The following is a description of a gene set: species: Homo sapiens Genes predicted to be targets of miRBase v22 microRNA hsa-miR-7-2-3p in miRDB v6.0 with MirTarget v4 prediction scores > 80 (high confidence targets). Human Gene Set: MIR7_2_3P from publication Chen Y, Wang X (PMID 31504780), and this is the list of marker genes: FRMD4B, GDF6, FSTL1, ZNF823, PCDH18, ACTR10, ACYP2, EXOC6, ZFYVE16, VGLL4, SGCE, BTN3A1, BCAP29, PIK3CB (phosphatidylinositol-4,5-bisphosphate 3-kinase catalytic subunit beta), CLCA4, NOD1, PPFIA2 (PTPRF interacting protein alpha 2), SENP7, ITGA4, HSP90AA1, TMEM245, DCAF13, EXOC5, HMGCLL1, ESM1, TXLNB, WFS1, FPR3, CADM2, ADNP2, IDH1, RBM12, TAFA2, PPARGC1A, SNTG1, PDE3B, FGF7, IFT57, CCNG2, ITIH6, HDAC2, SLC7A7, AHR, MEF2D, THEMIS, N4BP2L1, SH3BGRL2 (NCBI Gene Id 83699), TRPV3, EPS15, SLC13A1, ASB5, PRELID3B, MLF1, TENT5A, RBM7, STXBP5, MECOM, KLHL24, ZBTB10, TOR1AIP2, SPP1, STAM2, NKAIN2, ZMYND11, NUFIP2, LRRC58, ZNF626, CXADR, SKAP2, DPYSL2, TPD52L1, FZD8, EEF1E1, CHN2, TMEFF2, CEP170, DCAF7, POU3F1, PNRC1, CDH19, CHRNA6, SLC5A7, REEP3, NAP1L1, FGFR1OP2 (FGFR1 oncogene partner 2), MACROD2, SLC19A2, PELI1, GABRA4, CTNND2, RFX7, BNIP2, CPEB2, PTGFRN, PDLIM5, INO80D, FBXL3 (F-box and leucine rich repeat protein 3), SMARCA2, MUC13, GPM6A, GULP1, MPHOSPH9, CNOT6, TTYH3, DMRT1, PSMA5, RNF111, OTUD6B, FGF2, BTF3L4, TP53INP1, TRPC1, ARHGEF7, FMN1, ARHGAP5, PDS5B, LRBA, ATP1A2, CDK1, SLC35A3, CRABP2, ATL2, TXNRD1, CDC73, ATP8A1, TMEM41B, RPE, ANKRD46, PNLIPRP3, FN1, C12orf56 (chromosome 12 open reading frame 56), UPRT, POLR3A, CTDSPL2, GPR158, PER3, ZMYM2 (NCBI Gene Id 7750), PRR23B, YOD1, TAL1, FNIP1, GTF2A1, OXNAD1, NEUROD6, MINDY2, CCDC126 (NCBI Gene Id 90693), PLPPR4, MAPK9, MTDH, MYNN, FGL2, PPHLN1, NETO2, DDX6, ROBO2, SCG2, SLC39A8, RIMBP2, AGMO, TIMM21, NELL2, TMEM132C, CAB39 (NCBI Gene Id 51719), TMED2, PFDN4, MPC1, BCL11A, SLC6A2 (NCBI Gene Id 6530), ZFHX4, BTBD10, ELL2, FBXL17, FSD1L, TMX3, KDM4A, RMI1, RSPO3, ANGPTL3, USP37, SETD2, ART3, NCAPG2, SYT14, MYCN, CBLN4, GPR22, CFAP206, KCTD9, ANKRD13C, AEBP2 (AE binding protein 2, NCBI Gene Id 121536), FYB1, EBF2, VGLL3, YTHDF3, RNF139, RAB3C, ELF1, HTR2C, TMEM65, SRSF11, TOR1AIP1, DIP2C, PHF20L1, HAPLN1, SLC25A16, FRMD3, CASP8AP2, HYCC1, ENO2, GTF2H3, SESN3, CDC23, MGAT4A (alpha-1,3-mannosyl-glycoprotein 4-beta-N-acetylglucosaminyltransferase A), GRK2, SCYL3, ZCRB1, TASP1, MSX1, OLA1, RORB, ZNF519, POLR3G, NFE2L2, SEC23IP, RIF1, FAM169A, SLC17A6, ASF1A, PCDH11X, KALRN, MVB12B, MSL3, PIWIL1, NUDT5, CDK14, GPC4, MAP3K2, ZBTB20, FAN1, KLF3, NHSL1, DMXL2, CC2D2B, SPTSSA, NTN4, PTGS2, SEC14L1, MYEF2, ABHD13, CAMSAP2, AQR, CFAP65 (cilia and flagella associated protein 65), PPP3CA, THBS2, SLAIN1, SCAF8, MBNL2, CCNT2, HTATSF1, CREBBP (NCBI Gene Id 1387), ANTXR2, FXR1, PSD3, SLC12A2, HCFC2, ONECUT2, LRRFIP1, HINT3, CFHR2, RIMKLB, RBM46, RBMS3, C5orf24, TENT4B, ZC3HAV1L, ASTN1, CALCR, KIF13A, DCUN1D5, FBXO28, RAB3IP, ITGB6, NUCKS1, GPR137B, ZFR, PAX3, DCAF12L1, VEGFA, MYSM1, NUP58, LCLAT1, CNR1, CDH8, PJA2, VPS26A, GOLGA6L9, KLF12, SMIM14, SNCA, PICALM, ARMCX1, FBXO9, USF3, CBLL1, BEND4, PIGM, GMEB1, SPCS2, KSR2, THAP2, ATAD1, ZNHIT6, TNPO1, NAP1L2, NMT2, RPS6KA3, MAST4, DNAH14, C10orf88, TRIM2, NRXN1 (NCBI Gene Id 9378), RAB2A, C5orf47, TGFBR3, PDGFA, COPB1, SF3B1, KHDRBS2 (NCBI Gene Id 202559), TOR1A, THRAP3, CHM, ATRX, NEK7, MAP7, CCSER2, BRWD3, DLX2, ENDOV, KLHL15, EPB41L3, PLEKHG4, PPP2R5E, PLD5, TMEM47, KCNC2, ARHGAP12, JADE1, FBXO45, KCNK2, PTPRF, BDNF, FOXN2, GPR17, CLDN11, FAM184A, FBXO30, MB21D2, PTAR1, HDAC9, WIPF1, G3BP1, MORF4L2, POLDIP3, AMMECR1, AQP4, MBLAC2 (NCBI Gene Id 153364), CNTLN, PEX3, RLIG1, OSBPL8, SLC4A7, GMFB, EDIL3, ZNF23, DACT1, ARHGAP44, OPCML, MTSS1, TFAP4, HOOK3, MCEE, SPIN4, SLC10A7, IREB2, BCCIP, GPR19, TOPORS, SEL1L, GOPC, PTPDC1, TBC1D12, COPS7B, CCSER1 (coiled-coil serine rich protein 1), USP34, TMEM170B, RAPGEF6, AFF4, RPGRIP1L, MFAP4, HOXA5, TM9SF2, EPHA5, TRPM6, LARP4, EID1, EEA1, GPR180, PHF19 (PHD finger protein 19), BAZ1A, TMEM64 (transmembrane protein 64), NFATC1, ZNF780B, TM9SF3, UBE2E1, C2orf69 (chromosome 2 open reading frame 69), BLTP3B, ARHGEF12, FER, SLC25A24, DCUN1D3, FAM13C, IPMK, WDR48, NETO1, MIER3, PDE4D, RWDD3, LRRCC1, PTCD2, SLITRK4, USP14, RC3H1, TMOD2, PMS1, CACNB4, CDC27, PPP3R1, CDKN2B, ITPR2, IL1RAP, PGAP1, BTN3A2, REEP1, PRKAR1A, SATB2, MAT1A, TAOK1, CPEB4, UBE2V2, CTBP2, SLC30A5, PHC3, KCNH5, CSRNP1, ZNF273, CPE, TEAD3, ZNF638, STAU2, ACTA1, ADA2, MIB1, UFM1, CTLA4, RRM2, GJA1, HNRNPR, IMPACT, AGFG1, VPS41, SEC24A, ETNK1, PTP4A1, PEAK1, DENND1B, BCLAF1, IL13RA1, NIPBL, SLC9C1, C18orf63, CNOT7, CCDC50, CACNA1C, MCC, ASB7, TAFA4, ANK3, CDH20, CLASP1, TTC27, HNRNPA3, SSBP3, NOVA1, MIPOL1, DOK5, GRIA1, PCDH9, ARHGAP42, PDE5A, TMPRSS11A, GOLGA7, CASK, MED12, ACTR8, IMMP2L, MANEA, PRTG, CDH10, PRICKLE1, GAB1, ZNF544, GGPS1, PTPRA, TMEM30B, SREK1IP1, STX16, ZMYM5, FAT4, KIF5C, EIF4E (NCBI Gene Id 1977), GNB4, SMNDC1, DBI, EML5, MCU, CYTH1, TRIM32 (tripartite motif containing 32), CEP350, ALDH1L2, CYP26B1, AZIN1, RAB10, PDCD1LG2, AKAP6, SOS1, HSD11B1, PPP4R3A, BCL2L1, ABCB1, CBX5, FAXC, DICER1, PTPN4, SIAH1, ZFX, WDR76 (WD repeat domain 76), ZFP42, MAP3K5, LRP1B, HP1BP3, CAPRIN1, UNC5C, KHDRBS3, COL19A1, SCEL, TMEM33, CDC42SE2, TMX4, ACTR2, BZW1, GRIA3, TMEM220 (transmembrane protein 220), EIF3A, OR2L13, RALGPS2, RAB18, THSD7A, IFT70B, SPIN1, PAIP2, STEEP1, PRICKLE2, LMAN1, GABPB1, ZIC4, USP51 (ubiquitin specific peptidase 51), UHMK1, HSPA5, ITGB1, GPATCH2, BICRAL, ZNF280B, SANBR, CNMD, ZFHX3, RNF138, HERC2, MCOLN2, EXD1, MPL, ATXN7, TRAF7, GLCE, CMPK1, NANP, APC, PRKG1, ALCAM, HIVEP2, GUCY1A2, CXCL2, HCN1, SYNPO2, CAMTA2, FGF14, DPY19L3, SLC12A5 (NCBI Gene Id 57468), BMPR1B, CD2AP, TMEM181, MBNL3, CIAO2A, EIF5A2 (eukaryotic translation initiation factor 5A2), SENP6, PIAS2, KIAA0232, MAGT1, NPAS3, PLXNA4, PABPC5, NXPH2, ASB9, U2SURP, ZNF264, KDM4C, WDFY3, EDEM3, MED6, RNF19A, SDC2, CCDC88A, ZNF518A, RCSD1, TBC1D32, CCNY, COL4A1, SKIL, FAM91A1, ELOC, SATB1, KLF8, TRAF6, PHLPP1, ERI1, EGLN1, LRP12, SLC7A14, PPP1R9A, MAPK1IP1L, NAA15, DEK (NCBI Gene Id 7913), BHLHE22